The following is a description of a gene set: studied in species Mus musculus Reactome Pathway: Neuropilin interactions with VEGF and VEGFR part of: Signaling by VEGF electronically inferred by orthology from the curated human pathway This event has been computationally inferred from an event that has been demonstrated in another species.<p>The inference is based on the homology mapping from PANTHER. Briefly, reactions for which all involved PhysicalEntities (in input, output and catalyst) have a mapped orthologue/paralogue (for complexes at least 75% of components must have a mapping) are inferred to the other species., and this is the list of marker genes: Flt1